The following is a description of a gene set: Any process that modulates the rate, frequency or extent of pancreatic juice secretion, the regulated release of pancreatic juice by the exocrine pancreas into the upper part of the intestine. Human Gene Set: GOBP_REGULATION_OF_PANCREATIC_JUICE_SECRETION species: Homo sapiens, and this is the list of marker genes: SCT, WNK3, WNK1, NR1H2, WNK4, NR1H3, STK39